Given this list of marker genes MARCHF9, BCL2, TYSND1, ST6GALNAC6, FLT3LG, ANO9 (NCBI Gene Id 338440), UBASH3A, SPOCK2, ALG3, PELP1, JADE2, JAKMIP1, C10orf95-AS1, SCMH1, CMTR1 (cap methyltransferase 1), ZNF444, RNF220, MAMDC4, NOP14, MTRFR, RPL39L, CHIC1, LTK, LCAT, SBK1 (SH3 domain binding kinase 1), PAQR9, VEGFB, CTRL, CST6, GPM6A, LIME1, CBR3, MTG1, CRTC1, ZNF85, QRICH1, FAM120C, ACOT4 (acyl-CoA thioesterase 4), EMC3-AS1, CXCR3, BCL9L, LRRN3 (leucine rich repeat neuronal 3), TTC39B, GRAMD1C, CD5 (CD5 molecule), MAP3K14, ATXN7L2, LINC02899, NSD3, ST3GAL1, TRAV8-3, EEIG1, PCNX2 (pecanex 2), CABIN1 (calcineurin binding protein 1), ATP2B1-AS1, KLHL13, TUT1, WDR35, SH2D3C, ZNF827, DCAF4, CDIP1, MPV17L2, CCDC180, STYK1, CD6, CFAP45, FCMR, ANK3, DDX51, INO80C, TCOF1, TNFRSF25, CLUHP3, GIPC1, TRUB2 (TruB pseudouridine synthase family member 2), NOP2, PPIL2, SULF2, ALKBH5, RPS12, PSEN2, ABCG1, ENSG00000284691, TNFRSF4, SARM1, YDJC, TMEM14B (NCBI Gene Id 81853), USP53, ZNF154, MARS2, LINC00954, ZSCAN12, TGIF1, UTP20, RIMKLB, CAMK1D, TMEM161A, THEM4, DHX58, CLUH, CLPX, C14orf28, IL23A, SLC25A4, NR3C2, ALG12 (NCBI Gene Id 79087), ZNF506, PLEKHG4, MACROD1, DHRS3, PHEX, SOX12, ANKEF1, LETM1, USP36, SLC9A3-OT1, C10orf143, CYB5RL, DUBR, PAPOLA, UAP1L1, MRPS25, DISP1, UBTF, PATL2, ACY1, KLF8, PINX1, PCYT2, KLHDC4, KLF3, JHY, MEF2D, NT5E, AFG2A, PATJ, PRR12, EIF4EBP1, TAF4B, ID1, HPS4, NOSIP, ANXA2P1, EHMT2, TRIM3, SKI (SKI proto-oncogene), UNK, VSIG1, CERS4, FAM118A, PGGHG (NCBI Gene Id 80162), TARS3, CA6, LMF1, PDCD4, PDE4DIP, UNC5CL, NIPSNAP1, TMEM150A, GLO1, SURF2, NAT9, SLC16A10, MAP4K1, SMYD5, ZNF175, CBX7, POMGNT1, ETS1, KLRA1P, TRMU, TCF20, YY2, GPR183, KRI1 (KRI1 homolog), PEG10, MFHAS1, LAX1, GNPNAT1, L3MBTL2, EIF3B, DCK, PNO1, MSTO1, PDCD4-AS1, CACTIN, AARS2, KRTAP1-3, ANKRD23, PPP1R13B, ZNF682, SNPH, KAT2A, SOCS1, LRATD2, here is a description of the gene set: Genes up-regulated in ITGAM+ dendritic cells: wildtype versus IFNAR1. Murine Cytomegalovirus (MCMV) infection leads to early activation of various immune cells, including B and T lymphocytes, before the actual initiation of antigen-specific adaptive immunity. This activation is partly driven by innate cytokines, including type I interferon (IFN), which are induced early after infection. The objective of this study was to address the role of type I IFN in shaping early/innate B and T cell responses to a primary acute viral infection. In order to decipher the specific impact of IFN-I on cell subsets, we performed a genome-wide expression analysis on WT splenic B and CD8 T lymphocytes isolated from C57BL/6 mixed bone marrow chimera mice. This study complements series GSE39555, which focused on early responses of NK cells and of the two subsets of conventional dendritic cells. Human Gene Set: GSE45365_WT_VS_IFNAR_KO_CD11B_DC_UP studied in species Homo sapiens